The following is a description of a gene set: studied in species Homo sapiens A process carried out by the organs or tissues of the respiratory system. The respiratory system is an organ system responsible for respiratory gaseous exchange. Human Gene Set: GOBP_RESPIRATORY_SYSTEM_PROCESS, and this is the list of marker genes: CFAP54, GSX2, CCBE1, COL6A1, FLT4, HOXA5, TCF15, DNAH9, PHOX2B, FKRP, GLRA1, HIPK2, ADH5, STARD7, ATP1A2, NDN, ECEL1, ZFAND5, CFAP221, CC2D1A, FTO, CCDC88C, GAA, SPAG16, TNNC1, GLS, ADORA1, DRC1 (dynein regulatory complex subunit 1), MTG1, ODAD4, NLGN2, MTG2, NLGN3, TTLL1, TSHZ3, TLX3, RAB3A, YWHAZ, JAG2, STK40, DCAF11, AP3B1, DDIT3, CFAP43, SELENON, VANGL1, PBX3, BLOC1S6, MECP2, NEK10